Given this list of marker genes Ptk2, Ptpn13, Cbln1, Dkk1, Neurod2, Rhoa (NCBI Gene Id 51787), Tlr2, Epha7, Gsk3b, Apoe, Slit1, Mdga1, Arhgef15, Wnt5a, Ptn, Clstn3, Pgrmc1, Nfatc4, Robo1, App (NCBI Gene Id 319425), here is a description of the gene set: species: Mus musculus Mouse Gene Set: GOBP_NEGATIVE_REGULATION_OF_SYNAPSE_ORGANIZATION Any process that stops, prevents or reduces the frequency, rate or extent of synapse organization.